The following is a description of a gene set: from publication Lund R, Aittokallio T, Nevalainen O, Lahesmaa R (PMID 14607935) Genes up-regulated in CD4 T cells activated by anti-CD3 and anti-CD28: IL-12 (6h) versus untreated (6h). Th1 and Th2 cells arise from a common precursor cell in response to triggering through the TCR and cytokine receptors for IL-12 or IL-4. This leads to activation of complex signaling pathways, which are not known in detail. Disturbances in the balance between type 1 and type 2 responses can lead to certain immune-mediated diseases. Thus, it is important to understand how Th1 and Th2 cells are generated. To clarify the mechanisms as to how IL-12 and IL-4 induce Th1 and Th2 differentiation and how TGF-beta can inhibit this process, we have used oligonucleotide arrays to examine the early polarization of Th1 and Th2 cells in the presence and absence of TGF-beta after 0, 2, 6 and 48 hours of polarization. species: Homo sapiens Human Gene Set: GSE2770_IL12_ACT_VS_ACT_CD4_TCELL_6H_UP, and this is the list of marker genes: STK38, FARSB, MRPL55, PSMA5, PSMA3, PMS2P2, ENC1, DMWD, TATDN3, OMG, XPOT, COG5, RNASEH2C, ACTA1, GSN, RNF126P1, MESD, UCK2, RFT1 (NCBI Gene Id 91869), GTSF1, SEC11C, CELA2B, KCMF1, CCDC57, PIN4, RPL8, TEDC2, KCNF1, EHD1, RUVBL1, DUSP4, NOC4L, RBFOX2, PARP15, NDFIP2, GEMIN7, HGF, NDUFS6, SRRM2, PAM16, PSME2, ZFYVE27, SUN1, ZEB2, ATN1, MARCHF1, FASN, ESS2, RGS1 (NCBI Gene Id 5996), ZNF321P, UTP6, COPS5, SLC16A7, ATP6V0D1, VPS4A, RNASET2, HK1, SRR, CKS2, GABARAPL2, PAGE5, FYTTD1, PRR14, ZDHHC14, EBAG9, SURF4, ARAP1, TES, PRPF19, FCGR2B, ANAPC11, PTCD1, GHITM, SLC2A6, DNAJC19, RPL17, CDH17, MIF-AS1, ENO3, CLPP, RPS12, GFUS, RMND5B, UBE2G2, RCN3, PRMT2, CDKN1A, RGL2, YIF1A, DDB1 (damage specific DNA binding protein 1), KLHL22, PWP1, GPC1, ZNF777, CORO1A, SNHG1, TRAPPC8, HEBP1, PIR, PHOX2A, PPP1R14B, DUSP10, CLPTM1L, YY1AP1, ARF1, HERC2, STRADB, SFT2D1, LMO4, CSK, TMEM8B, KIF5B, TARS2, NAA60, NDUFS1, RGCC, JRK, SLC38A5, REPIN1, CYC1, RPPH1, UPB1, KCNH5, CFAP73, PSMD13, LRPAP1, GUCD1, RPP25L, BAG1, USP15, NIT2, LSM7, RHBDD2, RPL22, CYB5A (cytochrome b5 type A), TMED1, NDUFS2, ELAVL1, TWF1, AHRR, MPZL1, ACER3, PKMYT1, SSNA1, TMUB2, COX5A, SERPINB1, ELF4, SMARCA4, NKX1-1, INSR, TMEM59, TNFRSF11A, TMEM192, SPACA6, C1orf131, CCNDBP1 (cyclin D1 binding protein 1), TBC1D9B, PTPRE, TMEM14C, ATG2A, MCM6, VAMP3, NMUR1, SIGLEC6, MROH1, MIS18BP1, GOLGA8A, SQOR (NCBI Gene Id 58472), H4C2, SUV39H1, RASGRP2, BDH1, CSNK2A1, KCNN4, GTF2F1, MCM7, ZNF114, MRPL16, ZDHHC17, MON1A, INTS1, SNX18, RRP15 (NCBI Gene Id 57241), UBE2Z, UBE2C, EIF4H, SELENOS, ZNF407-AS1, NDUFA2, WDR55, PSMG3, TIMM10, ATP6V1H, LINC00865 (NCBI Gene Id 648270), IRF4